Given this list of marker genes AAAS, NDC1, TPI1, PFKFB4, PKLR, PPP2R1A, PGM2L1, PGAM2 (NCBI Gene Id 5224), NUP62, GCKR, PPP2R1B, ENO1, NUP107, PFKFB3, NUP133, TPR, ENO3 (NCBI Gene Id 2027), NUP42, PGK2, PFKFB2, GAPDHS, SEH1L, HK2, GNPDA1, RAE1, ENO2, PGAM1, PRKACA, NUP214, NUP210, GPI (NCBI Gene Id 2821), HK1, NUP153, PRKACB, NUP93, PPP2R5D, POM121, ADPGK, ENO4, PFKL (phosphofructokinase, liver type), PFKFB1, SEC13, PPP2CA, PKM, NUP98 (NCBI Gene Id 51457), NUP58, NUP50, NUP35, NUP155, PFKP, NUP160, NUP88, ALDOB, NUP85, HK3, NUP43, POM121C, ALDOA, GNPDA2, NUP188, PPP2CB, NUP37, BPGM, NUP205, PFKM, HKDC1, PRKACG, GAPDH, GCK, ALDOC, RANBP2, NUP54, PGK1, here is a description of the gene set: Reactome Pathway: Glycolysis The reactions of glycolysis (e.g., van Wijk and van Solinge 2005) convert glucose 6-phosphate to pyruvate. The entire process is cytosolic. Glucose 6-phosphate is reversibly isomerized to form fructose 6-phosphate. Phosphofructokinase 1 catalyzes the physiologically irreversible phosphorylation of fructose 6-phosphate to form fructose 1,6-bisphosphate. In six reversible reactions, fructose 1,6-bisphosphate is converted to two molecules of phosphoenolpyruvate and two molecules of NAD+ are reduced to NADH + H+. Each molecule of phosphoenolpyruvate reacts with ADP to form ATP and pyruvate in a physiologically irreversible reaction. Under aerobic conditions the NADH +H+ can be reoxidized to NAD+ via electron transport to yield additional ATP, while under anaerobic conditions or in cells lacking mitochondria NAD+ can be regenerated via the reduction of pyruvate to lactate. part of: Glucose metabolism species: Homo sapiens